Given this list of marker genes CIAO2A (cytosolic iron-sulfur assembly component 2A), PDGFB, POMP, CSGALNACT2, SELENOH, PTPA, NCAPG2, NUAK2, STMN1, SEL1L, NUCKS1, EEPD1 (endonuclease/exonuclease/phosphatase family domain containing 1), MYO1H (myosin IH), MAGOHB, CD40, PHKA1, ASAP2, LANCL2, UXS1 (UDP-glucuronate decarboxylase 1), NCAPG, PCTP, UBE2E3, DNAJB14, B4GALT6, PLA2G4A, CTSC, BIN3, PTPN3, LTBR (lymphotoxin beta receptor), UBE2F, LIG1, LYL1, YWHAG, VASP, UBL3, ATAD5, APOBEC3B, FAM234B, CDK1 (NCBI Gene Id 983), PNPO, TFEB, ACP2, MOB1A, ZNF229, STARD3NL, STRADA, BIRC3, IVNS1ABP, PURG, NOSTRIN, LIPE, IRAK2, BUB1B, NOD1, HAUS5, SPP1, FIGNL1, TMEM170B, BMP2 (bone morphogenetic protein 2), UBE2E1, CORO1C, ADORA2B, RCAN1, ERMP1, MALT1, TBC1D22A, SLC43A2, TUSC1, DIPK1A, KNSTRN, GPX1, PRKAR2A, CDYL2, NRROS, ESCO2, KRT80, RASGRP4, DIAPH2 (NCBI Gene Id 7989), ABHD6, UGDH, ATAD2, MDH2, ACSL1, CHKA, PRC1, RFC4, SMC2, LIMS4, TAX1BP3, TRIM36, VPS35, SERPINB2, AURKB, CENPU, NCAPD2, TJP2, TYK2, LPCAT2, WDR11, ST3GAL5, REL, SLC31A1, PHKA2, TLR3, DTX1, ABCB1, DENND4B, IFNAR2 (interferon alpha and beta receptor subunit 2), FAR1, GCNT1, CLPTM1, CAMTA2, RAD51, AURKA (aurora kinase A), ACTG1, CCDC181, G3BP1, RASGEF1B, B3GNT8, CEP55, OAT, DSCAM, GNG10, GCA, CCNA2, S100PBP, ID2, ZNF516, CACNB3, ABI3, GOLGA7, FSCN1 (NCBI Gene Id 6624), HPGDS, E2F7, SLC25A11, FH, ALG6, CADM3, NEURL2, RBPJ, SPC24, BRI3, NLRP10, TOPBP1, RCC1, XIAP, SERPINB7, TGFB1, ASNSD1, RGS3, ISCU, TLR2, POGLUT2, SLC66A3 (solute carrier family 66 member 3), PTPRE, WDR5B, ST3GAL4, ZNF600, IL1B, ARHGAP17, BMPR2, TNS1, SKP2, FADS6, B4GALT4, MPEG1, TCF19, HAT1, CEBPD, PMF1, CA9, DUSP16, SH3BGRL, BACH1, SDF2L1, SPINT1, CCRL2, PRKCB, MAPK7, GPR155, AKT1, NCKIPSD, IL12RB2, HSD3B7, RAP1A, FAM174A (NCBI Gene Id 345757), TPCN2, NMRAL1, MCM7, CDKN2C, SESN2, TMCC2, NECTIN4, DOCK10, CCNB2, ABHD15, SLC44A1, ZNF629, TKT, TRIT1, here is a description of the gene set: Genes down-regulated in transitional B lymphocytes: CR2 low versus CR2 high. from publication Suryani S, Fulcher DA, Santner-Nanan B, Nanan R, Wong M, Shaw PJ, Gibson J, Williams A, Tangye SG (PMID 19965666) Goals/objectives: to identify various gene expression in B cell subsets derived from human PBMC and cord blood Human Gene Set: GSE17186_CD21LOW_VS_CD21HIGH_TRANSITIONAL_BCELL_DN studied in species Homo sapiens